Given this list of marker genes Tomm7, Atg9a, Pgam5, Dync1li2, Tuba4a, Tomm6, Tomm40, Tomm22, Park7, Tomm20, Ube2l3, Tubb4b, Tbk1, Src, Dynll2, Tubal3, Vim, Tubb3, Tuba1b, Tubb2b, Optn, Map1lc3a, Pink1, Vdac2, Tomm70a, Tubb1, Cftr, Ubb, Dync1i2, Ube2d2a (ubiquitin-conjugating enzyme E2D 2A), Tuba1c, Ube2v1, Tubb2a, Tuba8, Mfn1, Ulk1 (NCBI Gene Id 22241), Atg12, Cetn1, Rps27a, Csnk2b, Pex5 (NCBI Gene Id 19305), Tubb4a, Dync1li1, Ubc (NCBI Gene Id 77003), Atg5, Arl13b, Vdac1, Sqstm1, Nbr1, Ube2n, Dynll1, Usp30, Hdac6, Map1lc3b, Fundc1, Tomm5, Uba52rt, Mterf3, Tuba1a, Uba52, Csnk2a2, Csnk2a1, Dync1h1, Tuba3b, Ube2d3, Mfn2, Tuba3a, Prkn, Vdac3, Atm, Dync1i1, Tubb6, here is a description of the gene set: Mouse Gene Set: REACTOME_SELECTIVE_AUTOPHAGY Selective autophagy studied in species Mus musculus